Given this list of marker genes Nudt16l1, Exosc10, Zcchc7, Nudt16l2, Nudt16, here is a description of the gene set: The chemical reactions and pathways resulting in the breakdown of snoRNA, small nucleolar RNA, any of a class of small RNAs that are associated with the eukaryotic nucleus as components of small nucleolar ribonucleoproteins. studied in species Mus musculus Mouse Gene Set: GOBP_SNO_S_RNA_CATABOLIC_PROCESS